The following is a description of a gene set: Any process that modulates the rate, frequency, or extent of inclusion body assembly. Inclusion body assembly is the aggregation, arrangement and bonding together of a set of components to form an inclusion body. Mouse Gene Set: GOBP_REGULATION_OF_INCLUSION_BODY_ASSEMBLY studied in species Mus musculus, and this is the list of marker genes: Dnajb8, Clu, Psmc6, Cdc34, Sacs, Nox1, Sncaip, Cdc34b, Dnajb2, Hsf1, Hspa2, Dnajb1, Psmc5, Hap1, Dnaja4, Apoe, Sorl1, Bag5, Dnajb6, Ifnb1, Hspa1b